Given this list of marker genes PHKG1, MYLK4, PHKG2, CAMK2B, CALM2, CAMK4, CAMK2A, MYLK, CALM3, MYLK3, CALM1, CAMK1D (calcium/calmodulin dependent protein kinase ID), MYLK2, CAMK1, CAMK1G, CAMKK2, CAMK2D, CAMKK1, CAMK2G (calcium/calmodulin dependent protein kinase II gamma), here is a description of the gene set: Pathway Definition from KEGG: Ca2+(cyto) -> CALM == CAMK Human Gene Set: KEGG_MEDICUS_REFERENCE_CA2_CAM_CAMK_SIGNALING_PATHWAY Ca2+/CAM-CAMK signaling pathway. Pathway ID: N01648. Pathway type: Reference. Pathway class: nt06528 Calcium signaling. studied in species Homo sapiens